The following is a description of a gene set: species: Homo sapiens The directed movement of substances from the Golgi to lysosomes. Human Gene Set: GOBP_GOLGI_TO_LYSOSOME_TRANSPORT, and this is the list of marker genes: RBSN, CCDC91, LAPTM5, AP1G1, GAK, AP4M1, EHD3, SORT1, ANKFY1, LAMP1, CLN3